The following is a description of a gene set: Germline mutations in the RET tyrosine kinase gene are responsible for the development of multiple endocrine neoplasia 2A and 2B (MEN2A and MEN2B). However, knowledge of the fundamental principles that determine the mutant RET-mediated signaling remains elusive. Here, we report increased expression of mitogen-activated protein kinase phosphatase-2 (MKP-2) in carcinomas developed in transgenic mice carrying RET with the MEN2A mutation (RET-MEN2A). The expression of MKP-2 was not only induced by RET-MEN2A or RET-MEN2B mutant proteins but also by the activation of endogenous RET by its ligand, glial cell line-derived neurotrophic factor (GDNF). MKP-2 expression was also evident in the MKK-f cell line, which was established from a mammary tumor developed in a RET-MEN2A transgenic mouse. Inhibition of MKP-2 attenuated the in vitro and in vivo proliferation of MKK-f cells, which was mediated by the suppression of cyclin B1 expression. Furthermore, we found that MKP-2 is highly expressed in medullary thyroid carcinomas derived from MEN2A patients. These findings suggest that the increased expression of MKP-2 may play a crucial role in oncogenic signaling downstream of mutant RET, leading to deregulation of cell cycle. from publication Hasegawa T, Enomoto A, Kato T, Kawai K, Miyamoto R, Jijiwa M, Ichihara M, Ishida M, Asai N, Murakumo Y, Ohara K, Niwa Y, Goto H, Takahashi M (PMID 18542059) Genes up-regulated in salivary, thyroid and mammary gland carcinomas developed in transgenic mice carrying RET allele with the MEN2A mutation (C634R). species: Mus musculus Mouse Gene Set: HASEGAWA_TUMORIGENESIS_BY_RET_C634R, and this is the list of marker genes: Ret, Serinc2, Slc35d3, Irf7, Cxcl1, Col11a1, Ifit1, Usp18, Dhx58